Given this list of marker genes WNT7A, DVL1, ADAM10, MAP2K1, TRAF6, GHSR, OLFM1, NLGN2, OGT, GPC4, MAPT, DAG1, RAP1A (NCBI Gene Id 5906), ABHD17B, IQSEC2 (NCBI Gene Id 4382), CLSTN3, TMEM108, ARHGAP44, HRAS, NETO2 (neuropilin and tolloid like 2), VPS26B, GRIPAP1, CACNA2D2, WNT5A, GABARAP, GPC6 (glypican 6), EPB41L3, KIF2C, DLG1 (NCBI Gene Id 1739), here is a description of the gene set: species: Homo sapiens Human Gene Set: GOBP_REGULATION_OF_PROTEIN_LOCALIZATION_TO_SYNAPSE Any process that modulates the frequency, rate or extent of protein localization to synapse.